The following is a description of a gene set: Human Gene Set: WP_CYTOKINECYTOKINE_RECEPTOR_INTERACTION species: Homo sapiens Cytokine-cytokine receptor interaction, and this is the list of marker genes: CXCL6, IL23R, CCL2, NFIC, LEP, NODAL, CCL4L2, IL7R, IL17RA, EDA (ectodysplasin A), IL2RG (NCBI Gene Id 3561), IFNGR2, IL17D, GDF5, IL31, IL11RA, INHBA (NCBI Gene Id 3624), GDF10, CXCL12, GDF1, IL36B, IL1RL1, IL36G, NGFR, CXCL16, CD40, ACKR4, MSTN, TNFSF15, TNFRSF10C, LIF, CCL23, BMP7, XCL1, CXCR6, CCL22, CSF2, IL13RA1, CXCL14, IL1RL2, IL13RA2, TNFRSF11A, CXCL11, IL5RA, INHBB, TSLP, EDAR, TNFRSF10A, CXCR5, IL22, CXCL10, AMHR2, GDF6, ACKR3, IFNK, IL17C, IL18R1, IL24, CSF3R, XCL2, IL9, CXCL2, IL31RA, IL34, CD27, TNFRSF1A, IL20RB, CXCL1, LTBR, CD70, CXCL8, CCL13, CCR8, BMP6 (NCBI Gene Id 7964), IL17RB, EPO, TNFSF10, CCL7, IL15, CD40LG, TNFRSF19, IL18, CCL14, BMP3, CCL1, TNFRSF25, PRL, IL17F, CCL20, IL1RAP, IL4R, IL23A (interleukin 23 subunit alpha), CCL21, INHBE, ACVRL1, TNFRSF21, EDA2R, TNFRSF17, BMP10, GH1, CCL28, CXCR1, BMP15, CCR7, TNFSF12, TNFSF9, TNFSF13B, TNFRSF18, CCR4, IL6ST, ANP32B, CCL18, IFNB1, ACVR1B, CXCR4, MPL, CCL15, GDF7, BMP5, IL21, TNFRSF14, IL4, LEPR, IFNLR1 (interferon lambda receptor 1), IFNL2, TNFRSF4, CSF1, CCL8, CSF2RB, GHR, GDF2, TGFB1, BMPR1B, CSF1R, CCL3, TNFSF4, TNFRSF1B, GDF3, CCR9, TNFRSF13B, IL10, GDF11, IL17RC, TGFBR1, GDF15, CCR2, IFNAR1, ACVR1, FASLG, IL33, IL27 (interleukin 27), IL1R1, TNFRSF8 (NCBI Gene Id 943), IL12RB2, IFNG (interferon gamma), IL27RA, CNTF, BMP8B, IL17A, GDF9, IL36RN, INHA, LTB, LTA, CSF3, IL19 (interleukin 19), CCR5, CCL4, CXCL5, CXCL9, BMPR1A, XCR1 (X-C motif chemokine receptor 1), IL15RA, CCL24, TNFRSF13C, IL20RA, BMPR2, CXCR2, CXCL17, IL1RN, IL1R2, CCL19, CXCL3 (C-X-C motif chemokine ligand 3), IL5, CCL5, IL7, CCL25, TNFRSF9, TNFSF14, IL6R, CX3CR1 (NCBI Gene Id 2836), IL10RA, PPBP, IFNW1 (interferon omega 1), IL2RA, INHBC, NGF, CCR1, IL3, IFNA2, CNTFR, TNFRSF10B, TNFSF11, PF4, IFNGR1, IFNL3, IL18RAP, CLCF1, IL37, IL25, CCR10, TNF, IL36A, IL17B, FAS, TGFB3, TNFRSF12A, IL10RB, ACVR2A, AMH, IL1F10, CCL27, TGFBR2, IL2, IL1A, LIFR, IL11, PRLR, BMP4, CCR6, ACVR2B, ACVR1C, IFNL1, IL20 (interleukin 20), CXCL13, GH2, IL22RA1, IL6, IL26, CCR3, CX3CL1, IFNAR2, PF4V1, TGFB2, IL21R, CCL26, IL13, CCL11, TPO, IL2RB, TNFRSF11B, IL12RB1, EPOR, RELT